Given this list of marker genes KCNE5, COQ10A, CLC, PSIP1, NETO2, DHRS3, NKAIN2, PEG10 (NCBI Gene Id 651242), GNAS, GK, BPTF, LAMA4, PLCB2, KBTBD8, MAMSTR, GHDC, ARRDC3, APBB2, CHRNB1, CDC42SE1, EPN2, EYA4, ARL5B, GSE1, SLC30A3, ZNF532, WNT2B, WDTC1, NOL4L, KCNIP3 (potassium voltage-gated channel interacting protein 3), EVX1, RAPSN, PITX3, KCNJ2, GRIN1, ITSN2, CBLN1, CHD4, GPRC5B, JUP, DGKD, ESCO1, TPPP3, DMD, GCAT, LGI3, GADD45G, DEGS2, CYRIA, COL1A1, EFNA4, PTPA, HSPB2, TMOD4, RNF121, RBM26 (RNA binding motif protein 26), CKM, GAB2, OTOS (NCBI Gene Id 150677), TBCC, POLR3GL (NCBI Gene Id 84265), TLK2, BCL7A, WDR20, ZNF800, PSD, ZNF326, AHI1, MUSK, LAMC2, HMGA1, TAB2, PPP2R2B, SEPTIN3, USO1 (NCBI Gene Id 8615), CADM1, HRC, FNDC5, LMTK2, MACROD1, RAPGEF4, GJB1, KCP, IRX5, CPEB3, ACVR1, KLHL23, KCNIP2, FEZF2 (FEZ family zinc finger 2), IGF2-AS, INTS9, KCNH5, TMEM165, RPL28, USP2, FHOD1, CHRND, CYLD, LDB3 (NCBI Gene Id 1219), GPR162, GOLGA4, SPOP (NCBI Gene Id 8405), RTN4RL2, IMPDH1, GRIK3, LRRC36, FITM1, DGKA, ELAVL4, EIF4ENIF1, C11orf87, DNAJB5, SELPLG, NRG2, ARMCX2, CAMK2G, DLX2, MARCHF5, TMEM185A, NAT8L (NCBI Gene Id 339984), ANKRD2, MID1 (midline 1), NOTCH1, MDGA1 (NCBI Gene Id 57164), EPHA2, CAST, CELA3A, LBX1, GARRE1, ASXL2, GGNBP2, CAMK1D, KCNQ4, PAX2, MYCLP1, CA7 (carbonic anhydrase 7), CITED2, MAST1, PTK7, WDR81 (NCBI Gene Id 780925), SLC39A5, DCT, GABRQ, SYT6, IGF2, TUBA4A, TUBA4B, TRPV3, PPP1R9B, LOXL4, MIR22HG, DIDO1, CRAT, NSG2, HMBOX1, C1QA, POU4F1, SERBP1, CYP26A1, SPATC1L, ZNF706, DGKZ, MMP11, JADE3, UNC45B, LARGE2, ACTA1, IKZF2, ANKHD1-EIF4EBP3, SCN5A, ARHGEF2 (Rho/Rac guanine nucleotide exchange factor 2), RNF213, SLC17A3, RTL9, MLLT11, CFL1, ATOH7, LARS2, TCEAL7, GUCY1B1, RUNX1, GPBP1 (NCBI Gene Id 65056), PDGFB, CRYAB, MASP1 (MBL associated serine protease 1), LRP6, ATP2A2, NKX2-5, PHACTR3, MKRN3 (NCBI Gene Id 7681), PRPF38B, CELA3B, JAZF1, FSCN2, PDLIM4, LINC00472, SPCS2, TMED9, ANKHD1, PABPC5, SH3GLB2, TNNI2, ELAVL3, ARHGAP36, USP32P2, NDST4 (N-deacetylase and N-sulfotransferase 4), FGF11, DSCAM, VDR, USB1, ALG10, CCDC85B, STX4, PLEKHA6, SKIL, ANKRD13B, H1-0, VPS13A, SLIT2, GRB2, EIF4G2, ARPP19, JPT1, LZTS2, JSRP1, SH3TC1, FGF8, SH3BP1, ENO3, CHD5, ADGRB2, TRIM39, ITGA6, IGF1, FBXL17, MYLIP, SPMIP6, CBFA2T3, SPI1, CNTN2, NFATC4, POU4F3, ANKRD1, SFTPC, ESRP2, FAM89B (NCBI Gene Id 23625), NADK2, MACF1 (microtubule actin crosslinking factor 1), PRDM8, KCNMA1, MARCHF8, AMPD2, SPACA6, here is a description of the gene set: studied in species Homo sapiens Genes having at least one occurrence of the motif NCACCTGYYNCNKN in the regions spanning 4 kb centered on their transcription starting sites. This matches the TCF3 transcription factor binding site V$E2A_Q2 (v7.4 TRANSFAC). Human Gene Set: E2A_Q2